Given this list of marker genes IRF7, TANK, UBC, TBK1, TICAM1, OPTN, TRAF3, TLR3, IKBKE, IRF3, UBB, UBA52, RPS27A, here is a description of the gene set: TICAM1-dependent activation of IRF3/IRF7 Human Gene Set: REACTOME_TICAM1_DEPENDENT_ACTIVATION_OF_IRF3_IRF7 species: Homo sapiens